Given this list of marker genes Kat2b, Tmem39a, Odf2l, Lima1, Gdi2, Mdm1, Cdk5rap2 (CDK5 regulatory subunit associated protein 2), Styxl1, Tesk1, Evi5l, Rbm14, Mfn2, Wdr44, Nbdy, Nupr1, Sec22b, Mak, Dnm2, Phf23, Arhgef2, Mtm1, Lrrk2, Usp10, Scfd1, Tbc1d7, Lpar1, Yap1, Trim32, Ccp110, Trim37, Cep97 (centrosomal protein 97), Smcr8, Kat2a, Limk2, Smad4, Cav3, Luzp1, Cdk10, Tchp, Becn1, Akt1, Kif24, Patl2, Tbc1d30 (NCBI Gene Id 77450), Pink1, Ehmt2, Fez2, Fez1, Marchf7, Mphosph9, here is a description of the gene set: Mouse Gene Set: GOBP_NEGATIVE_REGULATION_OF_ORGANELLE_ASSEMBLY studied in species Mus musculus Any process that stops, prevents or reduces the frequency, rate or extent of organelle assembly.